Given this list of marker genes HDLBP (NCBI Gene Id 7426), SCARB1, AMN (amnion associated transmembrane protein), CUBN, APOA1 (NCBI Gene Id 335), here is a description of the gene set: Clearance of circulating HDL particles involves particle binding to cell-surface SR-BI receptors, particle disassembly with rlease of pre-beta HDL (Silver & Tall 2001), and uptake of the latter mediated by cell-surface CUBN:AMN complex. part of: Plasma lipoprotein clearance species: Homo sapiens Reactome Pathway: HDL clearance